The following is a description of a gene set: Mouse Gene Set: GOBP_REGULATION_OF_CELL_FATE_SPECIFICATION Any process that mediates the adoption of a specific fate by a cell. studied in species Mus musculus, and this is the list of marker genes: Mbd3, Nanog, Fgf2, Pax6, Bmpr1a, Gfi1, Wnt3a, Mta2, Rbbp7, Mesp1, Esrp1, Gatad2b, Gatad2a, Mta3, Fgfr1, Hdac1, Rbbp4, Sfrp2, Chd4, Mta1, Sox17, Dkk1, Lmo4, Hdac2, Fzd7